The following is a description of a gene set: Human Gene Set: GOBP_PRENYLATION The covalent attachment of a prenyl group to a molecule; geranyl, farnesyl, or geranylgeranyl groups may be added. species: Homo sapiens, and this is the list of marker genes: FNTA, RABGGTB, CHM, FNTB, RCE1, AIPL1 (NCBI Gene Id 23746), RABGGTA, PLPP6, CHML, MUSK, PGGT1B (NCBI Gene Id 91374)